The following is a description of a gene set: studied in species Homo sapiens Any process that modulates the frequency, rate, or extent of the chemical reactions and pathways resulting in the breakdown of lipids. Human Gene Set: GOBP_REGULATION_OF_LIPID_CATABOLIC_PROCESS, and this is the list of marker genes: INS, ABCD2, PPARA, HCAR1, ABHD5, LDLR, FMC1, ADORA1, APOA2, ETFBKMT (NCBI Gene Id 254013), ENDOU, MIR127, AKT1, APOC1, THRA, APOA4, ALK, ANGPTL3, ABCD1, AADAC (arylacetamide deacetylase), AKT2, IDH1 (isocitrate dehydrogenase (NADP(+)) 1), PLIN5, SCARB2, PRKCD, MTLN, SIRT6, TNF, CLSTN3, APOA5, SCARB1 (NCBI Gene Id 949), TYSND1, MIR16-1, FUT1, LONP2, IRS1, MFSD2A, APOC3, MIR195, SCT, ADRA2A (adrenoceptor alpha 2A), GPLD1, RARRES2, APOC2, CIDEA, HCAR2, SORL1, TWIST1, IL1B, PDE3B (NCBI Gene Id 5140), ACACB, DAGLB, HPGD, BSCL2, PRKCE (protein kinase C epsilon), CPT1A, PNPLA2, PRKAA1, ABCB11, CIDEC, MLYCD, ENPP7, CRTC3, PIK3CG, IRS2